Given this list of marker genes Ugt1a7c, Ugt2b36, Ugt2b37 (NCBI Gene Id 112417), Slc35d1, Ugt2b34, Ugt1a2, Ugt2a3, Ugt1a5, Ugt1a6a, Ugt2a1, Ugt2b35, Ugt3a2, Ugt2b38, Ugt1a8, Ugt2b1, Ugdh, Ugt3a1 (UDP glycosyltransferases 3 family, polypeptide A1), Ugt2b5, Ugp2, Ugt2a2, Abhd10, Ugt1a1, Uxs1, Ugt1a9, here is a description of the gene set: species: Mus musculus Mouse Gene Set: REACTOME_GLUCURONIDATION Glucuronidation